Given this list of marker genes Zfp568, Gata2, Lif, Hes1, Hand1, Med1, Hey2, Tmed2, Plcd3, Crxos, Foxd3, Spint1, Plcd1, Ccn1, Pdgfb, Wnt2, Cdx4, Rtl1, Dnajb6, Csf2, Lef1, Grhl2, Itga4, Stk3, Cdx2, Cebpa (CCAAT/enhancer binding protein alpha), Krt8, Hsf1, Rbpj, Fzd5, Esx1, Cited2, Elf5, Mapk1, Igf2, Plk4 (NCBI Gene Id 99606), Socs3, Nsdhl, Eomes, Krt19, Setd2, Bmp5, E2f8, Hs6st1, Plac1, Esrrb, Egln1, Map2k1, Erf, Spint2, Tex19.1, Ascl2, Grb2, Taf10, Vcam1, E2f7, Adm, Hif1a, Egfr, Phlda2, Prdm1, Gjb5, Ncoa1, Ggnbp2, Synb, Syde1 (NCBI Gene Id 71709), Zfat, Ncoa3, Hey1, Stk4, Vash2, Zfp36l1, Trim28, Slc8a1, Llgl2, Pcdh12, Cebpb, Il10, Cited1, Ttpa, Snai1 (NCBI Gene Id 98875), Wnt7b, Sp1, Rspo3, Epas1, Akt1, Fbxw8, Nrk, Junb, Syna, Pkd1, Nfe2, Pcdha9, Hectd1, Mir127, Fgfr2, Pkd2, Senp2, Bptf, Gab1, Sox15, Bmp7, Cts7, Ncoa6, St14, Plg, Cts8, Gcm1, Itgav, Ovol2, Sp3, Nodal, Nr2f2, Tfeb, Sap130, Mdfi, Cdkn1c, Vash1, Xist, Arnt, Birc6, here is a description of the gene set: species: Mus musculus The embryonically driven process whose specific outcome is the progression of the placenta over time, from its formation to the mature structure. The placenta is an organ of metabolic interchange between fetus and mother, partly of embryonic origin and partly of maternal origin. Mouse Gene Set: GOBP_EMBRYONIC_PLACENTA_DEVELOPMENT